Given this list of marker genes Dynlt1f, Slc25a5, Rasip1, Slc25a4, Nol3, Bok, Bak1, Ier3, Heg1, Acaa2, Bcl2l1, Hk2, Bnip3, Slc25a31, Bcl2l2, Dynlt1a, Dynlt1b, Fzd9, Tmem14a, Slc35f6, Gclc, Dynlt1c, Mpv17l (Mpv17 transgene, kidney disease mutant-like), here is a description of the gene set: Mouse Gene Set: GOBP_NEGATIVE_REGULATION_OF_MEMBRANE_PERMEABILITY species: Mus musculus Any process that stops, prevents or reduces the frequency, rate or extent of the passage or uptake of molecules by a membrane.